Given this list of marker genes RAI1, ROR2, NOG, BMPR1B, WNT5A, BMP2, HOXD13, TFAP2B, RBBP8, DVL1, ERF, ATP6V1B2, GDF5, BHLHA9, SRCAP, IFT140, PUM1, PUF60, MYCN, TBX5, RUNX2, NIN, IGF2, GNB2, GJA1, here is a description of the gene set: Abnormality of the middle phalanx of the 5th finger studied in species Homo sapiens Human Gene Set: HP_ABNORMALITY_OF_THE_MIDDLE_PHALANX_OF_THE_5TH_FINGER